Given this list of marker genes TIMP1, LOXL3, NCAM1, THBS2, PDGFRB (NCBI Gene Id 5159), NEDD9, C2, FN1, MMP2, DCN, VEGFC, WNT2, LOXL1, LUM, FGFR1, ITGBL1, CXCL13, here is a description of the gene set: Cluster B: genes down-regulated in primary lung tumors driven by KRAS activation and loss of STK11; also up-regulated in human squamous cell carcinoma (SCC) vs adenocarcinoma subtype of NSCLC (non-small cell lung cancer). Germline mutation in serine/threonine kinase 11 (STK11, also called LKB1) results in Peutz-Jeghers syndrome, characterized by intestinal hamartomas and increased incidence of epithelial cancers. Although uncommon in most sporadic cancers, inactivating somatic mutations of LKB1 have been reported in primary human lung adenocarcinomas and derivative cell lines. Here we used a somatically activatable mutant Kras-driven model of mouse lung cancer to compare the role of Lkb1 to other tumour suppressors in lung cancer. Although Kras mutation cooperated with loss of p53 or Ink4a/Arf (also known as Cdkn2a) in this system, the strongest cooperation was seen with homozygous inactivation of Lkb1. Lkb1-deficient tumours demonstrated shorter latency, an expanded histological spectrum (adeno-, squamous and large-cell carcinoma) and more frequent metastasis compared to tumours lacking p53 or Ink4a/Arf. Pulmonary tumorigenesis was also accelerated by hemizygous inactivation of Lkb1. Consistent with these findings, inactivation of LKB1 was found in 34% and 19% of 144 analysed human lung adenocarcinomas and squamous cell carcinomas, respectively. Expression profiling in human lung cancer cell lines and mouse lung tumours identified a variety of metastasis-promoting genes, such as NEDD9, VEGFC and CD24, as targets of LKB1 repression in lung cancer. These studies establish LKB1 as a critical barrier to pulmonary tumorigenesis, controlling initiation, differentiation and metastasis. from publication Ji H, Ramsey MR, Hayes DN, Fan C, McNamara K, Kozlowski P, Torrice C, Wu MC, Shimamura T, Perera SA, Liang MC, Cai D, Naumov GN, Bao L, Contreras CM, Li D, Chen L, Krishnamurthy J, Koivunen J, Chirieac LR, Padera RF, Bronson RT, Lindeman NI, Christiani DC, Lin X, Shapiro GI, Jänne PA, Johnson BE, Meyerson M, Kwiatkowski DJ, Castrillon DH, Bardeesy N, Sharpless NE, Wong KK (PMID 17676035) studied in species Mus musculus Human Gene Set: JI_CARCINOGENESIS_BY_KRAS_AND_STK11_DN